Given this list of marker genes Psmd3, Psmd12, Ubr1, Psma2, Elp2, Psma3, Ubqln4, Txnl1 (NCBI Gene Id 53382), Zfand2a, Sem1, Psmb10, Psmd8, Usp25, Psmb8, Adrm1b, Psmc2, Psma5, Slc10a2, Psmc4, Psmd4, Psmc5, Psmb1, Psmd9, Psmb2, Psmd10, Psma4, Psma6, Psmd14, Psme1 (proteasome (prosome, macropain) activator subunit 1 (PA28 alpha)), Psmb9, Psmd1, Psme4, Psmb11, Psme3, Ubqln1, Prickle1 (prickle planar cell polarity protein 1), Psmd11, Psmb5, Psmd2, Uchl5, Psmd5, Psmd6, Ube3a, Ecpas, Psma1, Psmd13, Rad23b, Hspb1, Psmf1, Psma8, Rad23a (NCBI Gene Id 93802), Zfand2b, Psmd7, Vcp, Psmb3 (proteasome (prosome, macropain) subunit, beta type 3), Ide, Psmc6, Psmb4, Psmb6, Psmc3, Psma7, Adrm1, Usp14, Dnajb2, Psmc1, Psme2, Psmb7, here is a description of the gene set: A large multisubunit complex which catalyzes protein degradation, found in eukaryotes, archaea and some bacteria. In eukaryotes, this complex consists of the barrel shaped proteasome core complex and one or two associated proteins or complexes that act in regulating entry into or exit from the core. species: Mus musculus Mouse Gene Set: GOCC_PROTEASOME_COMPLEX